The following is a description of a gene set: species: Homo sapiens from publication Chen Y, Wang X (PMID 31504780) Human Gene Set: MIR4713_5P Genes predicted to be targets of miRBase v22 microRNA hsa-miR-4713-5p in miRDB v6.0 with MirTarget v4 prediction scores > 80 (high confidence targets)., and this is the list of marker genes: AGAP1, SESTD1, ELOVL3, NLRP7, FAM32A (NCBI Gene Id 26017), ZBTB4, CACNA1G, SZRD1, ZNF182, ZNF577, ENSA, EDEM1, SYNPO2L, TGIF2, LNPK, CACNA1E, ZNF596, IKZF2, PDE7A, ZNF568, DACT3, NRCAM, HEXIM1, ZNF385C, ZSWIM6, ANKRD12, ITGAX (integrin subunit alpha X), PTPN20, SPOPL, CNTLN, NEK2, SYNJ2BP, ARL6IP1 (NCBI Gene Id 56166), TAF5L, SYN2, ZNF135, PERP, IFT56, GOSR1, HOMER1, MEGF9, KCNE4, ZHX2, SV2B, RAD54L, IHH, SET, FADS1, CDH7, ZNF25, SAXO2, SRGAP3, MYOCD, KMT2A (lysine methyltransferase 2A), SNAP23, ZFP1, SLC49A4, TP53INP2, SHC4, ZKSCAN3, PALD1, CDKN1B, CYTH1, CYP4X1, DCAF6, KAZN, BSN, GPRC5B, FSHB, ZMYND8, CHRNB3, LRRC58, H1-0, IRAK2, INPP5A, TMEM108, NDC1, UBE2J1, PSTPIP2 (proline-serine-threonine phosphatase interacting protein 2), NFASC, ZEB1, TET3, PARD3B, MYB, TRIB1, SCD5, DOK6 (docking protein 6), POF1B (NCBI Gene Id 79983), SPOCK1, DUOX2, IPO5, C1orf21, CDK13, PIK3AP1, FRAT2, ZFX, C1orf198, ATP8A2, SNX30, FTO, LBH, OSBPL9, MLEC, ATP6V1H, KRBOX4, PIK3R1, ZNF99, GGNBP2, CHD2, LDLR, C22orf46P, ADIPOR2, SLC30A5, ZFP91, DYRK1A, ARHGEF28, GARIN1B, ZNF589, SMC3, CPD, PSMB6, ZC3H14, PPP1R1A, PRSS35, POM121C (POM121 transmembrane nucleoporin C), NOVA2, MTCH2, EIF5, PAPPA, CNOT7, TASOR, DENND4A, CD36, FAM47E-STBD1, RAB9A, POM121, AHI1, VPS26B, THUMPD3, SMDT1, MRPL36, C15orf48, ZNF700, PRR3, NKX2-4 (NK2 homeobox 4), EREG, GPR26, ZNF37A, CYP4A11, TDRP, DYNLT1, TNRC6B, TADA1, ADAM19